Given this list of marker genes Hdac4, Mup20, Reg1, Ppard, Nf1, Ecm1, Atxn1l, Il13, Cd40lg, Ppp3ca, Hey2, Anxa2, Prrx2, Vegfc, Taf4b, Agtr1a, Nrarp, Insm1, Cep131, Atxn1, Dicer1, Foxj2, Odam, Foxp1, Pth1r, Disp3, Bmp10, Pdgfrb, Hpse2, Smo, Eppk1, Esr1, Kdr, Tgfa, Ndufaf4, Cd1d2, Fgf7, Pdcd1lg2, Smarcc1, Hbegf, Cd38, Camp, Fgf8 (NCBI Gene Id 14179), Gpr183, Tcf3, Nfatc2, Rad51b, Nog, Tnf, Sapcd2, Flt4, Disc1, Wnt1, Anxa1, Tgm1 (transglutaminase 1, K polypeptide), Plxnb3, C5ar1, Hipk2, Shc1, Hdac6, Lrp6, Fbln5, Fadd, Kras, Ccn1, Tfrc, Npy5r, Mir24-2, Ccn4, Kitl, Fgf18, Sphk1, B4galt1, Rpl23, Prkaa1, Ern1, Smarca4, Fnta, Ccdc117, Cep43, Il15, Ccl2 (NCBI Gene Id 20296), Gdf2, Fabp4, Mir320, Thrb, Dkc1, Rarg, Tgfbr1, Ppp1cc, Irak4, Hmgb1, Arhgap5, Rara, Gnai2, Cysltr1, Dppa2, Extl3, Fosl2, Ccl11, Cntf, Camk2d, Il31ra, Mustn1 (musculoskeletal, embryonic nuclear protein 1), Plau, Pbxip1, Cdca7l, Cdc6, Ccpg1, Pdf, Rpa1, Cbx8, Serpinf2, Sox10, Vtcn1, Gsk3b, Acer2, H2-DMb1 (histocompatibility 2, class II, locus Mb1), Prl2c2, Tnfaip3, Il2, Pdcd6, Sash3, Bicra, Gper1, Cd46, Foxe3, Adm, Tbx1, Lrp2, Gnas, Slc25a5, Esm1, Ptprn, Jaml, Hmgb2, Zp3, Tmem250, Prkch, Htr1b, Stat5a, Il10, Prox1, Mmp12, Tox, Erbb3, Cdkn1a, Map2k5, Il7, Skp2, Alox12, Smarcd1 (SWI/SNF related, matrix associated, actin dependent regulator of chromatin, subfamily d, member 1), Ndufs4, Gak, Pramel7, Fgfr1, Tlr9, Btk, Trpm4, Fasl, Gata2, Ccar1, Mecp2, Stat3, Cdh13, Fbln1, Pak1, Tbx5, Pou1f1, Id1, Akr1b1, Atad5, Stx4a, Mdm2, Avpr1a, Mmp9, Cxcl1, Fgfr4, Yap1 (NCBI Gene Id 22601), Kif3a, Chp2, Lep, Bcar3, Adk, Fgf16, Gas6, Cxcl10, Thpo, S100b, Dnmt1, Prkcq, Bcl7a, Il6st, Sbno1, Fntb, Il13ra2, Fgfbp1, Ednrb, Nkx3-1, Rasal3 (NCBI Gene Id 320484), Nampt, Vegfb, Nckap1l, Fzd3, Il5, Ufl1, Nes, Wnt2, Rtkn2, Rab25, Gata4, Chrd, Lgals3, Mzb1, Cd40, Itgb3bp, Jcad, Havcr2, Insr (NCBI Gene Id 319666), Thbs1, Notch1, Nodal (NCBI Gene Id 21792), Pdx1, Epcam, Lrg1, Bex1, Bcl2, Ntn1, Ptger4, Dct, Col18a1, Mapk1, P2ry6, Hnrnpu, Romo1, Six1, Ccl24, Otp, Ccr3, Sp1, Fgf9, Lepr, Birc6, Gli1, Ptpn6, Rps15a, Fgf17, Itgax, Rbpj, Aif1, H2-T23, Lifr, Setd1a, S100a13, Sox8, Irgm1, Hes5, Edn2, Pura, Xrcc4, Thbs4, Rbpms2, Xbp1, Ccnd3, Abl1, Gjc2, Aspm, Ghr, Cyba, Vegfd, Sfrp1, St8sia1, Bmp2, Hck, Dpp4, Hspg2, Ptafr, Kdm5b, Pthlh, Il5ra, Fzr1, Pdcd2, Hrh3, Bmp6, Akr1c18, Fgfr3, Cck, Akirin2, Tgfb1 (NCBI Gene Id 21803), Bcl7c, Cip2a, Sox15, Fzd7, Folr2, Itga2, Ccl19, Zfpm2, Sox9, Vcam1, Hpse, Reg3b, Tlr4, Ghsr, Tirap, Rasgrf1, Cflar, Igf2, Gja1, Bloc1s2, Igfbp2, Pycard, Fgf20, Lif, Blm, Sdcbp, Rreb1, Ang6, Il6ra (interleukin 6 receptor, alpha), Il12a, Lhx2, Cd320 (CD320 antigen), Egr1, Vim, Ngfr, Bcl7b, Cd1d1, Plcg1, Cdk1, Cd4, Dhps, Scube2, Pgf, Tnfsf4, Rps6-ps4, Cd209c, Gli2, Ang2, Cdk4, Zfp335, Zfp580, Agtr1b, Recql4, Ilk, Plac8, Fgf21, Dysf, Prc1, Nr2e1, Pim1, Gli3, Ctf2, Apln, Smad4, Shank2, Drd3, Tpd52, Xcl1, Pnp, Egfr, Tgfb3, Il1a, Tnfrsf4, Bcl2l1, Gpr37l1, Kdm4c, Vhl, Gid8, Ddrgk1, Crlf2, Tial1, Cnot6l, Pitx2, Flt3 (NCBI Gene Id 269731), Stat1, Rnaseh2b, Klb, Vegfa, Ets1, Pramel1, Il11, Ascl1, Nlgn2, Mpl, Igf1, Trp63, Cripto, Mnat1 (NCBI Gene Id 320958), Cldn7, Grk2, T, Hras, Cdk2, Med1, Pik3ca, Dlg1, Tacr1, St6gal1, Hmga2, Cdc42, Nr4a1, Akt3, Sox11, Pdpk1, Pdgfa, Megf10, Erbb2, Pgr, Hmgn5, Tipin, E2f3 (E2F transcription factor 3), Lig4, Hyal1, Slc25a33, Prkaca, Malat1, Atf2, Ghrl, Cntfr (NCBI Gene Id 12804), Ell3 (elongation factor RNA polymerase II-like 3), Cd248, Tfap2b, Snhg15, Nacc1, Fgf22, Adam10, Mapk3, Pdgfd, Aplnr, Fgf23, Hif1a, Tbx2, Gata6, Dynap, Reg2, Il3, Ss18, Tgfbr2, Wdr77, Hdac1, Cst3, Dspp, Nbn, Runx2, Traf5 (TNF receptor-associated factor 5), Tgfb2, Pggt1b, Cyp7b1, Igfbp5, Shc4, Aqp1, Lef1, Irak1, Ang4, Grem1, Plag1, Tmem119, Ednra, Edn3, Phb1, F3, Nme1, Icosl, Il11ra2, Avp, Fermt2, Cxcr2, Anp32b, Bmp4, Wdr48, Tyk2, Hoxa3, Cd6, Itgb1, Fgf1, Oog2, Grn, Rnf187, Csf1r, Cd55b, Nck1, Tff2, Il34, Cd28 (CD28 antigen), Il2ra, Map3k3, Ctsh, Notch2, Hmx2, Pdcd10, Spn, Ctnnb1, Il23a, Il12b, Map3k5, Fgfr2, Flt1, Efemp1, Wdr62, Adora2b, Emp2, Htra1, Il11ra1, Bnc1, Mta3, Retn, Igf1r, Tnfsf13, Rictor, Fbxo5, Bmi1, Srpk2, Ccnb1, Cav2, Ager (NCBI Gene Id 11596), Sinhcaf, E2f1, Gas1, Hpgd, Rps3, Ntf3, Ssbp3, Carmil2, Foxp3, Fzd9, Ang5, Tspyl5, Ddx39b, Ccr2, Adamts1, Erbb4, Arrb2, Il6, Mtor, Acer3, Dlx6, Kif14, Foxm1, Nr5a2, Kat7, Cnot6, Nox1, Ada, Efnb1, Jak3, Tcf7l2, Bmp5, Fgf5, Cul4a, Six2, Clec7a, Csf3, Ptgfr, Ripk2, Garem1 (GRB2 associated regulator of MAPK1 subtype 1), Osr2, Ticam1 (NCBI Gene Id 224899), Mapk14, Cd81, Pth, Csf2ra, Pde4d, Cdc7, Areg, Ghrhr, Has2, Ptprc, Casr, Jak2, Csf2, Pla2g4a, Fgf4, Nqo2, Mydgf, Calr, Slc35f6, Osr1, Rasa1, Spdya, Mfn2, Pik3r1, Ppp1r16b, Edn1, Prl2c3, Mlxipl, Rasip1, Epo (erythropoietin), Btnl2, Cckbr, Irs1, Dhx9, Npy, Cd274, Gng5, Dmrta2, Fndc3b, Rac2, Myd88, Slc7a1, Slc7a5, Cd86, Cdh3 (cadherin 3), Cav1, Itgav, Ccn2, Il12rb1 (interleukin 12 receptor, beta 1), Lbh, Ar, Stxbp4 (NCBI Gene Id 320264), Prkd1, Crkl (NCBI Gene Id 68624), Selenon, Derl2, Marcksl1, Srsf6, Ereg, Ash2l, Slamf1, Fbxw4, Brd9, Rps9, Ins2, Ptpn22 (NCBI Gene Id 19260), Ddr2, Pold4, Ocstamp, Bambi, Rassf10 (Ras association (RalGDS/AF-6) domain family (N-terminal) member 10), Pdcl3, Prdx3, Timp1, Tbx3, Agt, Foxp2, Agap2 (ArfGAP with GTPase domain, ankyrin repeat and PH domain 2), Vash2, Ghrh, Ppargc1a, Ptk2, Ccl26, Bad, Adgrg1, Fam98a, Il1b, Efnb2 (ephrin B2), Wwtr1, Vav3 (NCBI Gene Id 99531), Arrb1 (arrestin, beta 1), Card11, Ccne1, Tnc, Myb, Pml, Scg2, Atp7a, Ifng, Cd55, Osmr, Crnn, Dab2ip, Nccrp1, Pla2g1b (phospholipase A2, group IB, pancreas), Drd2, Dll4, Trpc5, Serpine1, Tshr, Sox2, Fn1, Slc39a10, Dynapl1, Selenok, Bst1 (NCBI Gene Id 269647), Il24, Ccdc88b, Icmt, Eapp, H2-DMb2, Nanog, Gata1, Kmt2c, Il4, Rps6kb1, Kit, Actl6b, Tgfbr3, Shmt2, Cdc20, Cxadr (NCBI Gene Id 70446, coxsackie virus and adenovirus receptor), Nolc1, Fer, Isl1, Ftmt, Nkx2-5, C3ar1, Ntrk2, Tgif1, Ldlrap1, Il21, Traf6, Meis2, Gnaq, Abcc4, Twist2, Itgb3, Id4 (inhibitor of DNA binding 4), Epgn, Nod2, Kdm1a, Tnfrsf13c, Esrp2, Epha4, Wnt3a, Aqp11, Ccnd2, Irs2, Nr4a3, Aldh3a1, S1pr1, Actl6a, Ihh, Epor, Egr3 (NCBI Gene Id 13655), Osm, Mapk8, Azin1, Bmyc, Rps4x, Cd74, Mycn, Ryk, Mir702, Rogdi, Ins1, Crlf1, Prkci, Apela, Peli1, Sirt6, Ptgs2, Scn5a, Prl, Spta1, Gpam, Optn, Ntrk3, Paxbp1, Tbx20, Id2, Ikbkb, Pdgfra, Ccl5, Glul, Gnai3, Pdgfb, Aldh1a2, F2r, Pou3f2, Crip2, Egf, Cdx2, Enpp2, Smarca2, Htr2a, Hlx, Reg3d, Pten, Cldn1, Nmb, Sts, Fam98b, Insl3 (insulin-like 3), Cldn5, Flna, Src, Cdk6, Rela, Tnfsf13b, Dmd, Tsc22d1, Shh, Cd59a, Tbx18, Nck2, Ltbp3, Csf2rb, Wnt5a, Agtr2, Zmiz1, Hes1, Mdk, Mif, Kif20b, Ncam1, Gab2, Ighd, Tjp1, Itga4, Trf, Fbrs, Vsx2, Elane, Cops9, Mir205, Cd80, Cnot7, Zfp703, Twist1, Pax3 (paired box 3), Avpr2, Mmp2, Reg3g, Prkca, Smarcd3, Uts2, Cav3, Hmgcr, Btc, Cd59b, Gfap, Tiam1, Itpr1, Mst1, Prkd2, Prok1, Itgal, Shox2, Bmpr1a (NCBI Gene Id 68748), Fgf15, Htr2b, Tspo, Prkcz, Prlr, Bicral (BRD4 interacting chromatin remodeling complex associated protein like), Ptn, Sulf1, Meis3, Mapk15, Cib1, Sfrp2, Fgf6, Ncor1, Glce, Frs2, Mab21l2, Suz12, Glp1r, Nras, Lyn, Cox17, Zap70, Tert, Pax7, Ptk2b, Reg3a (NCBI Gene Id 19694), Nme2, Oog1, Clcf1, Mas1, Sirt1, Brk1, Phip, Actb, Lamc2, Lta, Slc25a27, Odc1, Chrnb2, Myocd, Kmt2d, Hmox1, Nap1l1, N4bp2l2, Fgf10, Nrg1, Rptor, Atf3, Slc4a1, Notch3, Arnt2, Saal1, Scx, Gdf9, Mef2d, Klf5, Foxf1, Adcyap1, Ezh2, Rprd1b, Map3k7, Wnt10b, Tslp, Prkra, Emc10, Csnk2a1, Cxcr3, Cd209d, Cx3cr1, Flt3l, Oog3, Ccnd1, Gcnt2, Adam17, Hdac2, Cnot8, Grk5, Tac1, Aggf1, Nmbr, Arg1, Vip, Cd47, Syk, Vstm2a, Cthrc1, Tgm2, Lin28a, Gdnf, Clec11a, Pid1, Clu, Stat5b (signal transducer and activator of transcription 5B), Ccr7, Cnbp, Cd244a, Il12rb2, Ngf, Sema5a, Ephb2, Mab21l1, Wnt7a, Rsu1, Cxcl12, Bcl6, Dot1l, Marchf7, Sox4, Pbx1, Mdm4 (transformed mouse 3T3 cell double minute 4), Serpinb7, Csf1, Tnfsf9, Il18, Jun, Ang, Mir223, Eya1, Kcnn4, Maz, Foxg1, Stx3, Cd3e, Meis1, Rps6, Dll1, Mef2c (NCBI Gene Id 71350, myocyte enhancer factor 2C), Pax2, Lgmn, Cacul1, Hipk1, Tns3, Comp (cartilage oligomeric matrix protein), Ccna2, Fgf2, Tlx1, Pou3f3, Ctc1, Cd24a, Pkhd1, Rtn4, Ighm, Il23r, Esrp1, Myc, Orc1, Itgb1bp1, Pax6, Mir24-1, Uts2r, Hpn, Epha1, Il7r, Cd209e, Prkdc (protein kinase, DNA activated, catalytic polypeptide), Cx3cl1, Acvrl1, Gpbar1 (NCBI Gene Id 227289), Wnt7b (NCBI Gene Id 22422), Pitx3, Csf2rb2, Fxn, Ltf, Hdac5, Adrb2, Cd276, Prrx1, Cdkn1b, Npm1, Carm1, Akt1, Egfl7, Sphk2, Dlx5, Iqgap3, Mir744, Mvd, Coro1a, Prmt1, Lrp5 (NCBI Gene Id 16973), Syf2 (NCBI Gene Id 68592), Smpd3, F2, Ptprz1, Kcna5, Etv5, Zfp143, Txnl4b, Nkx2-6, Calcrl, Dnaja3, Gkn1, Hilpda, Fgf3, Pdgfc, Cdc25a, Pik3cd, Hcls1, Crh, Cdon, here is a description of the gene set: Mouse Gene Set: GOBP_POSITIVE_REGULATION_OF_CELL_POPULATION_PROLIFERATION Any process that activates or increases the rate or extent of cell proliferation. studied in species Mus musculus